The following is a description of a gene set: species: Homo sapiens Human Gene Set: GOBP_REGULATION_OF_UBIQUITIN_PROTEIN_LIGASE_ACTIVITY Any process that modulates the frequency, rate or extent of ubiquitin protein ligase activity., and this is the list of marker genes: RPL11, RPL5, RPS7, BTRC, MAD2L2, MAD2L1, RPL23, PLK1, FZR1, CDKN2A, FBXO5, SKP1 (S-phase kinase associated protein 1), UBE2S, USP44, UBE2C, CDC14B, CDC20